Given this list of marker genes PTPN1, ACP1, PTPN18, PTPN6, PTPN9, PTPN22, PTPN2, PTPN4 (protein tyrosine phosphatase non-receptor type 4), DUSP22 (dual specificity phosphatase 22), PTPN7, PTPN12, PTPN11, here is a description of the gene set: species: Homo sapiens Human Gene Set: GOMF_NON_MEMBRANE_SPANNING_PROTEIN_TYROSINE_PHOSPHATASE_ACTIVITY Catalysis of the reaction: non-membrane spanning protein tyrosine phosphate + H2O = non-membrane spanning protein tyrosine + phosphate.